The following is a description of a gene set: More than one fracture of the ribs. Callus formation around multiple rib fractures can produce a row of multiple rounded expansions (beadlike prominences) giving the appearance of beaded ribs. Note that rachitic rosary would have one bead per rib (a swelling at the costochondral junction), while beaded ribs in the context of multiple rib fractures have multiple beads (fractures) along the same rib. Human Gene Set: HP_MULTIPLE_RIB_FRACTURES Multiple rib fractures studied in species Homo sapiens, and this is the list of marker genes: CREB3L1, SERPINH1, CRTAP, TNFRSF11A, TRIP11, PHEX, COL1A2, COL1A1, TAPT1, LBR, PPIB